Given this list of marker genes HOXD13, PCNT, AMER1, DNMT3B, FRG1, DUX4, SMCHD1, DUX4L1, here is a description of the gene set: Straight clavicles studied in species Homo sapiens Human Gene Set: HP_STRAIGHT_CLAVICLES An abnormally straight configuration of the clavicle, a tubular bone which normally is doubly curved.